The following is a description of a gene set: species: Homo sapiens Human Gene Set: REACTOME_G_ALPHA_I_SIGNALLING_EVENTS G alpha (i) signalling events, and this is the list of marker genes: NMUR1, CCR9, HTR1E, CXCR5, CXCL16 (C-X-C motif chemokine ligand 16), PDE1C, GNAI1, GPER1, TAS2R5, GABBR2, S1PR5, POMC, NMS, NPBWR1, PPP2CB, CX3CR1, GNAS, HTR1B (5-hydroxytryptamine receptor 1B), C3AR1, S1PR3, RGS22, OPRL1, RXFP3, PPP3R1, PDYN, GPR55, NMUR2, CCL28, HTR1D, CXCL12, CCL4, ADORA1, CASR, CCR4, AGTR2, ANXA1, TAS2R30, RGS9, FPR3, CXCL13, GALR1, APLN, PDE4C, TAS2R1, HRH4, CXCR6, GRM4, ADCY4, GNAT3, GRM3, PPP3CC, CCR8, OPN1LW, HCAR3, NPY4R, BDKRB1, HTR5A, NPW, PENK, RLN3, NPBWR2, ADCY6, CXCL11, CCR7, NBEA, PNOC, TAS2R50, CAMK2D, NPY1R, CCL19, GNB3, BDKRB2, HCAR2, C5, PRKX, SSTR4, PF4, MTNR1A, TAS2R38, TAS1R2, RGS14, PLCB2, PRKCG, PLCB3, PDE1A, TAS2R42, P2RY4, PPBP, TAS1R1, OPN5, C3, SRC, GALR3, ADCY3, HCAR1, OPN3, RGSL1, SST, GPR31, GNG7, PMCH, CCL5, PPP2R1A, GPR183 (G protein-coupled receptor 183), C5AR1, SSTR2, GNA15, PRKAR1A, CCL20, RGS7, DRD3, RGS8, GNAT1, GNG5, NPY, CCR6, CCL1, OPRM1, GNAT2, CXCL1 (NCBI Gene Id 2919), TAS2R41, NPY2R, GRM7, CXCL6 (NCBI Gene Id 6372), GPR17, RGS1, ADRA2A, TAS2R3, RHO, CAMK2A, CXCR3, PRKACA, CXCL3, CXCR1, PRKCA (NCBI Gene Id 5578), PRKAR2A, ITPR1, GNAI3 (NCBI Gene Id 2773), AHCYL1, CCL25, RGS13, ADRA2C, CCL4L2, GPR37, GNGT2, PRKACG (protein kinase cAMP-activated catalytic subunit gamma), PTGDR2, TAS1R3, TAS2R40, PDE4D, TAS2R14, ADCY5, OPRK1, SSTR1, APLNR, GNG4, S1PR2, OXGR1, MCHR2, RGS18, GNGT1, MTNR1B, ADCY7, TAS2R9, PRKACB, CAMK4, FPR2, RGS19, PPP2R1B, CCL21, GRM8, TAS2R16, P2RY12, CXCR4, ADRA2B (NCBI Gene Id 151), PTGER3, ADCY2, TAS2R46, HTR1F, INSL5, RGS17, CAMKK1, PCP2, TAS2R8, TAS2R39, GNG8, GNB2 (G protein subunit beta 2), RGS5, P2RY14, MAPK1, LPAR2, PRKCD, OPRD1, ADCY9, GNG2, RGR, ITPR3, CXCL9, PDE1B, GNG11, RGS12 (regulator of G protein signaling 12), GNAI2, OPN1SW, S1PR4, PPP2CA, CCR10, GPR18, PPP1CA, RGS3, PYY, PPY, SSTR5, PPP1R1B, SSTR3, GPSM1, GRM2, CCR1, TAS2R13, CXCL8, ADCY1, CNR2, CORT, OXER1, PLA2G4A, GNAL, PPP3CB, CDK5, RGS6, CCL13, AGT, GNG10, SAA1 (NCBI Gene Id 6288), MCHR1, GABBR1, GNG3, FPR1, NPY5R, P2RY13 (NCBI Gene Id 53829), GNG12, GAL (galanin and GMAP prepropeptide), GPSM2, CNR1, CREB1, SUCNR1, ITPR2, NPB, CCL16, CCR5, CAMK2G, PLCB4, CXCR2, TAS2R31, NMU, CCL27, GNAZ, APP, GNA14, GNB4, TAS2R4, PPP2R5D, GNAQ, LPAR1, GRM6, CAMK2B, GRK2, CALM1, RRH, RGS10, PDE4A, HEBP1, PSAP, RGS20, GNA11, LPAR5, CX3CL1, ACKR3, RGS4, GNG13 (G protein subunit gamma 13), TAS2R20 (NCBI Gene Id 266660), PRKAR2B, CHRM4, ADORA3, DRD4, ADCY8, GPR37L1, PLCB1, CXCL10, OPN1MW, PPP3CA, CCR2, CHRM2, GALR2, PDE4B, CCR3, RGS21, CXCL2, TAS2R19, KPNA2, RXFP4, GNB5, GNB1, CCL23, RGS16, CAMKK2, PRKAR1B, TAS2R60, TAS2R10, LPAR3, CXCL5, TAS2R43, RGS11, TAS2R7, KNG1, GPSM3